Given this list of marker genes PARP1, PARP10, TNKS, PARP6, PARP3, PARP11, TNKS2, PARP2, PARP16, PARP8, PARP12, here is a description of the gene set: studied in species Homo sapiens Human Gene Set: GOBP_PROTEIN_AUTO_ADP_RIBOSYLATION The ADP-ribosylation by a protein of one or more of its own amino acid residues, or residues on an identical protein.